Given this list of marker genes Trim8, Chmp3, Trim12a, Mid2, Trim26, Trim32, Trim15, Pml, Trim13, Trim56, Trim21, Marchf2, Trim28 (tripartite motif-containing 28), Vapb, Trim30c, Trim27, Trim25, Trim35, Trim30a, Trim5, Trim30b, Trim11, Trim30d, Trim12c, here is a description of the gene set: Mouse Gene Set: GOBP_SUPPRESSION_OF_VIRAL_RELEASE_BY_HOST species: Mus musculus A process in which a host organism stops, prevents or reduces the frequency, rate or extent of the release of a virus with which it is infected, from its cells.